Given this list of marker genes MPHOSPH8, TLE1, H2AC4, SMARCA4, ZMYM2, H3C15, H2AJ, EED, TGIF2, CTBP1, H2BC17, H4C1, PKM, MCRIP1, HDAC1, H2BC9, WT1, SIRT1, H2AB1, KMT5A, TCF3, TWIST2, H2AC20, ZBTB33 (zinc finger and BTB domain containing 33), H2BC21, EZH2, H2BC11, DNTTIP1, ZEB1, TWIST1, H2BC5, H2BC4, H2AC18, RBBP7, H2AC7, MAPK3, H3-3A, H2BC12L, H2BC14, CDH1, H2BC26, TCF12, CTBP2, H2AX, FOXQ1, H2BC13, H2AC6, H2AC14, HDAC2, MAPK1, H2BC12, ZEB2, SUZ12, SNAI1, KDM1A, ZNF217, H2BC3, RBBP4, H2BC1, SNAI2, H3C1, H2AZ2, H2BC15, here is a description of the gene set: studied in species Homo sapiens part of: Regulation of CDH1 Gene Transcription Reactome Pathway: Negative Regulation of CDH1 Gene Transcription <p>Numerous transcription factors have been identified as direct negative regulators of transcription of CDH1 gene (also known as E-cadherin, epithelial cadherin, Cadherin-1, CADH1, or uvomorulin). Only those transcription factors reported to repress CDH1 gene transcription in at least two studies, in at least one directly, have been annotated in this pathway. These include CTBP1 and CTBP2, DNTTIP1, FOXQ1, the polycomb repressor complex PRC2 (EZH2), SNAI1 (SNAIL), SNAI2 (SLUG), TCF3, TCF12, TGIF2, TWIST1, TWIST2, WT1, ZBTB33, ZEB1, ZEB2, and ZNF217.</p><p>Transcription factors implicated in direct repression of CDH1 gene transcription by a single study are not shown in the pathway diagram. These include AR, SOX30, GATA1, MIER3, TBX3, KLF8, and GRHL3.</p><p>Hepatitis B virus (HBV)-encoded X antigen (HBx) downregulates CDH1 gene transcription by recruiting the SIN3A:HDAC histone deacetylase complex to the Snail-binding sites in the human CDH1 gene promoter. Hepatitis C virus (HCV) core protein facilitates binding of SNAI1 to the CDH1 gene promoter and the consequent downregulation of CDH1 gene transcription. Hexavalent chromium Cr(VI), a carcinogen associated with lung diseases and lung cancer, represses CDH1 gene expression through activation of CDH1 gene repressors such as SNAI1, ZEB1, and KLF8, and enhancing the binding of HDAC1 to the CDH1 gene promoter.</p><p>Downregulation of the CDH1 gene expression is one of the hallmarks of epithelial-to-mesenchymal transition, seen normally during development and wound healing, but also pathologically, during cancer progression. Expression of many negative regulators of the CDH1 gene is controlled by TGF-beta signaling, prostaglandin E(2) signaling, WNT signaling, and NFκB signaling.</p>